Given this list of marker genes GSK3A, YY1, MIR200B (NCBI Gene Id 406984), MIR19A, PTEN, RGS2, MIR199B, CTDP1, MIR17HG, MIR590, PPARA, RUNX1 (NCBI Gene Id 861), CAV3, ARX, DUSP6, SOD1, FOXC2, WT1, TBX2, CACNA2D2, MEF2C, RAG2, RBP4, STK4, IGF2, MIR222, ACACB, MYH6, MIR199A1, ERBB4 (erb-b2 receptor tyrosine kinase 4), PAK1, BASP1, STK3, EDN1, NKX2-5, TP73, NOTCH1, TGFBR1, TBX5 (T-box transcription factor 5), MIR204, FGFR2, WWC2, GLI1, JARID2, VGLL4, NOG, PI16, KCNK2, TBX20, YBX3 (NCBI Gene Id 8531), WWC3, HEY2, ZFPM2, HLX, SAV1, RBPJ, BCL2L11, WWC1, BMPR1A, FXN, CGA, LATS2, FGFR1, MAPK14 (mitogen-activated protein kinase 14), FOXC1, TOMM70, YAP1, CCNB1, SLC6A4, NRG1, MIR208A, MIR548C, WNT2, AKAP6, RGS4, COL14A1, SMO, TGFBR3, PARP2, PIM1, GATA6, MIR25, FLVCR1, FOXP1, MIR509-1, CDK1, AKT1, FGF9, IGF1, SERP1, FGF8 (NCBI Gene Id 2253), MIR873, MAEL, G6PD, MIR1-1, LATS1, MAPK11, IL7, SASH3, PROX1, BMP10, MIR19B1, FGF20, FGF2, here is a description of the gene set: Human Gene Set: GOBP_REGULATION_OF_ORGAN_GROWTH Any process that modulates the frequency, rate or extent of growth of an organ of an organism. species: Homo sapiens